Given this list of marker genes Prmt5, Prmt8, Prmt9, Prmt1, Carm1, Prmt2, Prmt6, Prmt7, Ndufaf7, here is a description of the gene set: studied in species Mus musculus Mouse Gene Set: GOMF_HISTONE_H4R3_METHYLTRANSFERASE_ACTIVITY Catalysis of the reaction: S-adenosyl-L-methionine + (histone H4)-arginine (position 3) = S-adenosyl-L-homocysteine + (histone H4)-N-methyl-arginine (position 3). This reaction is the addition of a methyl group to the arginine residue at position 3 of histone H4, producing histone H4R3me.